The following is a description of a gene set: Interleukin-35 Signalling studied in species Homo sapiens Human Gene Set: REACTOME_INTERLEUKIN_35_SIGNALLING, and this is the list of marker genes: STAT1, IL6ST, TYK2, STAT3, JAK1, IL27RA, EBI3, STAT4, CANX, IL12A, IL12RB2, JAK2